Given this list of marker genes LINC00900, CD163, CPT1A, PPT1, LMNA, DDAH2, TUBA1C, OTULINL, PTGFRN, SLC66A3, MPC1, RNASE2, TNRC18, RBP7, MS4A3, NPL, GGA2, RNF130, SNX17, ARFGAP2, BCKDHA, ACLY, SRSF4, ARHGAP6, SCAMP2, EEPD1, FIBP, LPCAT2, FAM32A, RMND5A, JDP2, COX14, MPP1, LZTS2 (leucine zipper tumor suppressor 2), CIAO2A, RHOT1, ADAP2, ZNF784, FN1, DNAJB1, PRPF40A, MACF1, RGL1, ADI1, SAE1, RCBTB2, CAPNS1 (calpain small subunit 1), UTRN, VPS26B, UROS, PLPBP, CHSY1, CEBPD, PIP4K2A, HEATR5A, NTMT1, GPS2, KIAA0513 (NCBI Gene Id 9764), ABHD8, MLEC, IMPA2, CCDC112, PFKFB4, HNRNPLL, SUOX, C5AR2, ABHD6, S100A4, VPS45, CACUL1, FOXRED1, IDH2, VSIG4, CALCOCO1, CCS, GPR65, LIPA, CSF3R, ABHD12, SLC25A20, RNF135, PHKA2, GLUD1, VAMP8, FUCA1, REV3L, SLC37A2, PHPT1, SNX24, STIMATE, UHRF1, PMF1, ALYREF, DNMT1, SWSAP1, SLC22A5, FAM13A, DSTYK, CD84, BMF, AIF1, TMEM39B, POLR2J, JPT1, MNDA, CD9, AP2M1, TMED10, PARL, BLVRB, GAL3ST4, REPS2, HS3ST1, RFXANK, PLA2G15, FAM135A, TMEM134, CD36, RPS27L, TLR4, RNASE1, PON2, SRRT, EDNRB, AGO1, CHN2, RUSC1, PDK4, PHTF2, SPIDR, C1orf162, ATRN, XPA, DRAM2, CHRAC1, GPN3, REEP4, ACBD5, IFT25, NACC2, THRAP3, OLFML2B, PCNA, ITGB5, DRAP1, RNF114, DEPDC7, NUDT16L1, TRIM14, BRCC3, TMT1A, MEF2C, CALHM2, NDUFC1, CENPB, ZNF503, NCKIPSD, CMTM7 (NCBI Gene Id 112616), A1BG-AS1, NUDT9, GTF2F1, MFSD13A, SLC46A2, PAK1, MARCHF1, ATP6V0D1, CD101, CLEC10A, RPAP3, CD1E, CUEDC2, ZDHHC7, ATPAF1, POLH, GRK3, FCN1, HEATR3, PLA2G4A, TM2D2, TEX2, IDH3G, LSM10, TNFRSF11A, CRYL1, TUBA1A, CD302, RASA1, ANKS1A, ABHD11, MERTK, TUBA1B, ABCD3, AP2A2, NFXL1, HSD17B10, TACC1, UBAC1, MRPL20, here is a description of the gene set: studied in species Homo sapiens Human Gene Set: GSE30971_CTRL_VS_LPS_STIM_MACROPHAGE_WBP7_HET_4H_DN Genes down-regulated in bone marrow-derived macrophages with heterozygous MLL4 knockout: control versus treated with LPS for 4h. from publication Austenaa L, Barozzi I, Chronowska A, Termanini A, Ostuni R, Prosperini E, Stewart AF, Testa G, Natoli G (PMID 22483804) Histone methyltransferases catalyze site-specific deposition of methyl groups, enabling recruitment of transcriptional regulators. In mammals, trimethylation of lysine 4 in histone H3, a modification localized at the transcription start sites of active genes, is catalyzed by six enzymes (SET1a and SET1b, MLL1–MLL4) whose specific functions are largely unknown. By using a genomic approach, we found that in macrophages, MLL4 (also known as Wbp7) was required for the expression of Pigp, an essential component of the GPI-GlcNAc transferase, the enzyme catalyzing the first step of glycosylphosphatidylinositol (GPI) anchor synthesis. Impaired Pigp expression in Wbp7-/- macrophages abolished GPI anchor-dependent loading of proteins on the cell membrane. Consistently, loss of GPI-anchored CD14, the coreceptor for lipopolysaccharide (LPS) and other bacterial molecules, markedly attenuated LPS-triggered intracellular signals and gene expression changes. These data link a histone-modifying enzyme to a biosynthetic pathway and indicate a specialized biological role for Wbp7 in macrophage function and antimicrobial response.